Given this list of marker genes WDR73, GNB1, GRIK2, ASXL3, CDK5, COG8, TPM2, L1CAM, GLE1, GTPBP2, SLC6A9, BLTP1, SYNE1, MAPT, CNTNAP1, NEB, SCYL2, ATP6V1E1, KIDINS220, MYOD1, GALC, BICD2, NR4A2, MOGS, WWOX, SMG9, KCNA1, DST, TBR1 (T-box brain transcription factor 1), BCOR, HNRNPH1, FLNB, TOR1A, PSAP, here is a description of the gene set: An abnormal hand posture in which the hands are clenched to fists. All digits held completely flexed at the metacarpophalangeal and interphalangeal joints. In prenatal sonography of the fetal clenched hand, the index finger overlaps a clenched fist formed by the other digits. The proximal interphalangeal articulation of the index finger is flexed and ulnarly deviated, and the thumb is adducted. Human Gene Set: HP_HAND_CLENCHING Hand clenching studied in species Homo sapiens